Given this list of marker genes Zfp148, Lgalsl, Pxn, Lpin2, Tyr, Tgs1, Vcf1, Slc30a6, Slc16a4 (solute carrier family 16 (monocarboxylic acid transporters), member 4), Pja2, Ppp2ca, Lmx1a, Trim26, Msl1, Rps24, Mprip, Uba6, Dcaf1, 0610030E20Rik, Npat, Neb, Lrp11, Radil, Acacb (NCBI Gene Id 97267), Gak, Gata3, Cox16, Trim44, Lsamp (NCBI Gene Id 414117), Plk2, Gsk3b, Tent4a, Papss1, Anxa10, Rwdd1, Coro1c, Myt1l, Mid2, Mamdc2, Wdfy3, Pdpk1, Nmt2, Sh2d3c, Itsn1, G3bp1, Abhd17b, Irs1, Hspa9, Prl7a2, Herc6, Add3, Zfand5, Kmt2d, Akap6, 2700097O09Rik, Esp3, Nxt2, Ginm1, Stk38, Erich1, Tjp1, Crbn, Treml2, Zbtb9, Cnot6, Dio2, Cited2, Mecp2, Tln2, Magohb, H3f3b, Rbm6, Usf3, F8a, Cd93, Acsl5, Kcnk2, Kntc1, Cebpb, Chkb, Adgra3, Amacr, Cnn3, Rpl29, Ccne2, Asb3, Dmrt3 (NCBI Gene Id 240590), Fbxw2, Rpgr, Blzf1, Sat1, Zic1, Dmac1, Wipf3, Efcab12, Stag1, Arl8b, 1700123K08Rik, Plat, Slc30a5, Pwwp2a, Pla2r1, Zfp248, Pip5k1b, Proser1, Plxnc1, Tmx3, Pcyox1, Pnpla6, Tcp11, Hgf, Ptprc, Brcc3dc, Zfhx4, Bcl3 (NCBI Gene Id 12051), Sorbs1, Wfdc18, Lars1, Rnf220, Chic2, Togaram1, Hoxa5, Krt86, Epc2, Taf1d, Rtn4rl1, Rubcn, Fbxo28, Krtap3-1 (NCBI Gene Id 69473), Spire1, Unk, Osbpl3, Ceacam20, Akain1 (NCBI Gene Id 320722), Trpv1, Traf3ip3, Plg, Fmnl2, Chd6, Bpifa3, Rab33b, Slc27a2 (solute carrier family 27 (fatty acid transporter), member 2), Dio3, Sox5, Tor2a (NCBI Gene Id 30933), Sumf1, Prkra, Copz2, Bmper, Chpt1, Rfx8, Pknox1, Rnft1, Larp4b, Trank1, Igdcc4, Ap3s1, Irx1, Zfp882, Ly9, Rmdn3, 5730409E04Rik, Dicer1, Cd226, Snrpb, Golph3, Tnrc18, Celsr2, Pogk, Slco5a1, Col12a1, Selenop, Mindy2, Olfm3, S2bpcox16, Arpp21, Metap2, Klf4 (NCBI Gene Id 269540), Sfrp2, Galnt13, Map2k4, Slc5a8, Vdac1, Ewsr1, Snrpg, Ntn1, Brca1, Tc2n, Nemf, Snx18 (NCBI Gene Id 218636), Tmem176a, Rps6ka1, Wfdc17 (WAP four-disulfide core domain 17), Vps51, Tspan5, Sparcl1, Gm11541, Esp16, Ehmt1, Psmb9, Lysmd2, Phtf2, Itpk1, Acly, Tecta, Phlpp1, Zbtb43, Ndufa6, Immp1l, Dtd2, Gpr174 (NCBI Gene Id 213439), Slc15a2, Esp18, Brk1, Elovl5, Ppara, Rb1, Trappc1, Rbbp9, Tmem38b, Tmeff2, Ier3ip1, Kalrn, Cpeb2, Ckb, Muc2, Azi2, Mansc1, Eloc, Tbc1d15, Trub1, Gls2, Pgr, Iqub, Tm9sf2, Eva1a, Plekhg1, Cd209g, Macf1, Cyp26b1, Cox7c, Hoxa4, Grhl2, Psapl1, Bicd1, Krt10, Erlec1, Krtap7-1, Dmxl2, Mal, Pum2, Samsn1, Fndc3a, Rpap3, Clec4e, Isca2, Csmd3, Ldb2, Nfat5, Tab3, Atxn1l, Slc9a9, Zbtb44, Senp5, Pex13, Krtap4-1, Dusp14, Atp11c, Zmym2, Ankib1, Arhgef5, Samd5, Esp15, Slc25a13, Map3k8, Galc, Slc66a3, Cdc34, Ndufaf4, Mxd1, Aqp4, Pex3, Htr1a, Glt8d2, Rufy3, Rangrf, Adam30, G2e3, Chek1, Ccdc125, Gria4, Uqcrh, Stk4, Zkscan6, Hnf1b, Fam171a1, Septin11, Gmnn, Nrxn1, Lin52 (lin-52 DREAM MuvB core complex component), Ugt2b35, Dnm2, Krtap15-1, Dclre1b, Bhmt2, Uaca, Atp8a1, Tbc1d2b (TBC1 domain family, member 2B), Cdh9 (NCBI Gene Id 12565), Ccp110, Zswim6 (zinc finger SWIM-type containing 6), Zxdb, Kidins220, Calr4, Camk2d, Zfp704, Fbn1, Ssbp2, Haspin, Pak1, Prrg1, Rfpl4, here is a description of the gene set: Mouse Gene Set: MIR_21B species: Mus musculus Genes predicted to be targets of miRBase v22 microRNA mmu_miR_21b in miRDB v6.0 with MirTarget v4 prediction scores > 80 (high confidence targets). from publication Chen Y, Wang X (PMID 31504780)